The following is a description of a gene set: species: Homo sapiens Human Gene Set: REACTOME_PROTEIN_LIPOYLATION Protein lipoylation, and this is the list of marker genes: NDUFAB1, LIPT1, DLST, DBT, GCSH, LIAS, DLAT, FDX1, LIPT2, NFU1